The following is a description of a gene set: Any process that modulates the frequency, rate, or extent of an acute inflammatory response. Mouse Gene Set: GOBP_REGULATION_OF_ACUTE_INFLAMMATORY_RESPONSE species: Mus musculus, and this is the list of marker genes: Ins2, Ptgs2, F12, Alox5ap, Il1b, Ptges, Ccr5, Fcgr2b, Dnase1l3, Adcyap1, Nlrp3, Il6, Fcgr3, Tnfrsf11a, Adora1, Pik3cg, Tac1, Cnr1, Fcgr1, Tnf, Ighg2b, Fut7, Pla2g2d, Adam8 (a disintegrin and metallopeptidase domain 8), Fcer1a, C2cd4b, Gstp1, Fcer1g, Ffar2, Ighg1, Tnfsf11, H2-T23, Spn, Ccl5, Ccr7, Selenos, Il4, Ffar3, C3, Pparg, Ptger3, C2cd4a (C2 calcium-dependent domain containing 4A), Ins1, Npy5r, Btk, Ash1l (NCBI Gene Id 352974), Zp3, Ednrb, Aoc3, Dnase1, Il20rb, Park7, Rhbdd3, Npy